Given this list of marker genes RSBN1L, ERBB4, RAB1A, HIPK1, MARK1, AQP3, KIT, RIT2, PCMTD1, FXN, ZMYM2, INA, SYBU, CLGN, DPP8, PHACTR4, ZFP36L2, ZNG1A, GRB10, APOLD1, GRIK1, CREBL2, C3orf70, MRAP2, CDK19, SBK1, FGF14, GDF9, AKAP5, SNX4, SHLD2, CASZ1, IRF2, NAA25, RFX3, TCF12, GALNT3, FNDC3A, PPP2R2A, SEC62, HMBOX1, GUCY1A2, DNAJC6, MARF1, ESR1, ANKRD12, ZFYVE16, C6, KDR, EIF3J, UBE2J1, ARHGEF38, POGZ, PLXNC1, CDKN1B, CCDC18, DCAF12, SYNCRIP, VASH1, ATAD2B, KIF20A, SNRNP48, ADAM22, EIF5A2, ZNG1F, BEND4, ZNF385A, ATOSA, EML6, PGPEP1L, RFX8, CASR, TRPC3, AP3B2, PIEZO2, RDX, SUN2, GABRG1, AGTPBP1, C6orf118, SYT10, TUB, PLCL2, RIMS3, ZNG1C, LYPLA1, RNF4, RFX7, FNIP2, VAPB, ZNF615, ZNG1E, TGS1, TLE3, TDRP, HECTD2, KIF16B, PAF1, ZNF91, FOXN2, RBP2, PIK3R1, ZFPM2, BEAN1, SEMA3C, SLC4A7, DPH6, PPP3R1, TUBA1A, KLF7, SNAP29, PAIP1, RNPS1, WNK3, NXPH1, DMRT3, HNRNPH3, ATXN1, LBR, SANBR, TNRC6C, WDR35, SESN3, ZNG1B, MIDN, GPBP1, TP53BP2, TSPAN13, MIER3, NYAP2, CLRN1, NIPAL4, MYLIP, SVIP, BCL2L11, CDH2, ASPA, TSC22D3, SLC2A13, BICDL1, BBC3, WDR47, NRK, SMARCA5, GNAI3, GABRA1, IRX5, DENND1B, FMR1, RGS6 (regulator of G protein signaling 6), ZNF181, FERMT2, LUZP2, L3MBTL1, TFG, PANK3, CLVS2, ATP1B1, CXCL12, TMCC1, DDIT4, ARF4, MYBL1, PRRC2B, ETV3, RAB18, USP27X, BRWD1, BRWD3, CHSY1, CTDSPL2, DCUN1D1, AIDA, LHFPL2, CCN1, POLR3E, MIA3, NAP1L5, here is a description of the gene set: Genes predicted to be targets of miRBase v22 microRNA hsa-miR-221-3p in miRDB v6.0 with MirTarget v4 prediction scores > 80 (high confidence targets). from publication Chen Y, Wang X (PMID 31504780) Human Gene Set: MIR221_3P species: Homo sapiens